Given this list of marker genes Fignl1, Slc45a4, Sox6, Egr3, Col5a1, Fkrp, here is a description of the gene set: from publication Chen Y, Wang X (PMID 31504780) Mouse Gene Set: MIR_1188_3P studied in species Mus musculus Genes predicted to be targets of miRBase v22 microRNA mmu_miR_1188_3p in miRDB v6.0 with MirTarget v4 prediction scores > 80 (high confidence targets).